The following is a description of a gene set: The p53 tumour suppressor functions as a transcriptional activator, and several p53-inducible genes that play a critical proapoptotic role have been described. Moreover, p53 regulates the expression of various proteins participating in autoregulatory feedback loops, including proteins that negatively control p53 stability (Mdm2 and Pirh2) or modulate stress-induced phosphorylation of p53 on Ser-46 (p53DINP1 or Wip1), a key event for p53-induced apoptosis. Here, we describe a new systematic analysis of p53 targets using oligonucleotide chips, and report the identification of dapk1 as a novel p53 target. We demonstrate that dapk1 mRNA levels increase in a p53-dependent manner in various cellular settings. Both human and mouse dapk1 genomic loci contain DNA sequences that bind p53 in vitro and in vivo. Since dapk1 encodes a serine/threonine kinase previously shown to suppress oncogene-induced transformation by activating a p19ARF/p53-dependent apoptotic checkpoint, our results suggest that Dapk1 participates in a new positive feedback loop controlling p53 activation and apoptosis. Mouse Gene Set: MARTORIATI_MDM4_TARGETS_FETAL_LIVER_UP species: Mus musculus from publication Martoriati A, Doumont G, Alcalay M, Bellefroid E, Pelicci PG, Marine JC (PMID 15608685) Genes up-regulated in non-apoptotic tissues (fetal liver) after MDM4 knockout., and this is the list of marker genes: Llph, Bhlhe41, Naa20, Prrc2c, Chac1, Vwf, Luc7l2, Ano3, Srrm2, Krt19, Elp6, Igf2bp1, Hbb-bs (hemoglobin, beta adult s chain), Lsm7, Ddx3y, Nme4, Vldlr, Commd2, Ptk7, Map3k20, Mapkapk3, Tmem45a, Arap2, Snrpg, Zic2, Plekha2, Cav1 (NCBI Gene Id 12389), Rap2a (RAS related protein 2a), Tfap4, Siva1, Dapk1, Tmem63b, Fam162a, Kdm5d, Mix23, Pfkp, Nme2, Ndufa7 (NADH:ubiquinone oxidoreductase subunit A7), Zfp433, Mfap3, Tap1 (transporter 1, ATP-binding cassette, sub-family B (MDR/TAP)), Ifitm3, Ero1a, Coa8, Hk2, Perp, Tagln, Def6, Snord104, Kcne3 (NCBI Gene Id 80572, potassium voltage-gated channel, Isk-related subfamily, gene 3), Rnf169, Ankrd37, Pmaip1, Prelid2, Eif4ebp1, Rb1, Ppp1r3g, Pdxp, Tmem143 (transmembrane protein 143), Etv4, Gins1, Sesn2, Glrx3, Susd4, Rev1, Ark2c, Mnat1, Pfkl, Ndrg1, Synm, Nrn1, Lmnb1, Higd1a, Cpt1c, N4bp1, Stc2, Trp53inp1 (transformation related protein 53 inducible nuclear protein 1), Zmat3, Rps18, Pgm1, Pde2a, Kank3 (NCBI Gene Id 80880), Lage3, Hoxb5os, Wdr36, Ei24, Pidd1, Raly, Pitpnc1, Egln3, Pitpnm2, Mtg1, Slc6a14, Bloc1s2, Hilpda, Susd6, Fam114a2, Ddit4, Atp5f1e, Cdkn1a, Foxo3, Garin5b, Hspbp1, Npm3 (nucleoplasmin 3), Ddias, Zbtb16, Btg2, Slc66a3, Ccn2, Ptprv, Tmem256, ENSMUSG00000127189, Enho, P3h2, Pgk1, Ciart (circadian associated repressor of transcription), Mab21l3, Ccp110, Cdc34b, Kdm7a, Mdm2, Ube2k, Kifc1, Dus4l, Mir219a-2, Rhbdf2, Pik3ip1, Nudt5, 2010204K13Rik, Ak1, Dpm3, Usf1, Dyrk3, Cenpw, 1810014B01Rik, Pltp, Cgref1, Phlda1, Upp1, Exoc4, Hoxd4, Lrrc32, Car12, Bola2, Ddit4l, Eno1, Them6, Zfp688, Kbtbd11, Prtg, Pdk1, Ndufb9, Clcn3, Adm, Serpine2, Fam181b, Eda2r, Grip1, Lrrfip1, Ptp4a3, Nsmce1, Sap30, Rprm, Rap2b, Aen, Pde4b, Ak4, Mgarp, Spag17, Wdr54, Slc16a3 (solute carrier family 16 (monocarboxylic acid transporters), member 3), Galk1, Zfp365, Plcd4, Cpne2, Psrc1, Jag2, Cep170b, Fabp7, Eola1, Fsd1, Trim6, Btg3, Jdp2, Bnip3, Ccng1, Arrdc3, Apaf1, P4ha1, Timm8b, Pigp, Atp5mk, Egln1, Ptpn14, Pom121, Sp6, Mt2, Abhd4, Hoxb9, Pigf, Sostdc1, P4ha2, Cd81, Gbe1, Cox7a2, Immp1l, Tagap, Nampt, Rps12, Ppp1r3c, Dcxr, Ascl2, 2410006H16Rik, Phlda3, Wtip, Glul, Rnf19a, Fat1, Nppb, 2900060B14Rik, Rpl34, Wnt6, Gnb1, Kmt2e, Bnip3l, Hprt1, Eif2s3y, Cox6b2, Nr6a1, Pakap, Slc19a2, Ier3, Rab5c, Dlx3, St14, Bhlhe40, Plod2, Hoxd1, A2m, Ccnc, Fbxw9, Wipi1, Sec61g, Dynll2